The following is a description of a gene set: studied in species Homo sapiens The increase in size or mass of a skeletal muscle. This may be due to a change in the fiber number or size. Human Gene Set: GOBP_SKELETAL_MUSCLE_TISSUE_GROWTH, and this is the list of marker genes: MTM1, DLL1, VPS54 (VPS54 subunit of GARP complex), CHRNA1, ACTN3, CHRND (cholinergic receptor nicotinic delta subunit), MSTN (NCBI Gene Id 2660), NACA, IGF2 (NCBI Gene Id 492304), TLL2, COL6A1